The following is a description of a gene set: This event has been computationally inferred from an event that has been demonstrated in another species.<p>The inference is based on the homology mapping from PANTHER. Briefly, reactions for which all involved PhysicalEntities (in input, output and catalyst) have a mapped orthologue/paralogue (for complexes at least 75% of components must have a mapping) are inferred to the other species. electronically inferred by orthology from the curated human pathway part of: O2/CO2 exchange in erythrocytes studied in species Mus musculus Reactome Pathway: Erythrocytes take up oxygen and release carbon dioxide, and this is the list of marker genes: Car4, Hbb-bt, Aqp1, Slc4a1